The following is a description of a gene set: studied in species Homo sapiens Autophosphorylation of the insulin receptor triggers a series of signalling events, mediated by SHC or IRS, and resulting in activation of the Ras/RAF and MAP kinase cascades. A second effect of the autophosphorylation of the insulin receptor is its internalisation into an endosome, which downregulates its signalling activity. part of: Signaling by Insulin receptor Reactome Pathway: Insulin receptor signalling cascade, and this is the list of marker genes: FGF3, SOS1, GAB2, PIK3CA, FGF23, THEM4, GAB1, FGF5, AKT2, FGFR2 (NCBI Gene Id 2263), FGF20, MAPK1, HRAS, FGF7, KRAS, KL, FGF22, FGF8, IRS2, SHC1, FGFR3, PIK3R2, PIK3R4, FGF17, GRB10, FGF4, PDE3B, MAPK3, FGF2, NRAS, GRB2, PIK3CB, FGF16, FGF6, FGF10, INSR, FGF9, FGF18, TRIB3, PIK3C3, FGFR4, FGFR1, PTPN11, FLT3, IRS1, INS, TLR9, PDPK1, FGF19, FLT3LG, KLB, PIK3R1, FRS2, FGF1